The following is a description of a gene set: Any process that activates or increases the frequency, rate or extent of protein localization to synapse. studied in species Mus musculus Mouse Gene Set: GOBP_POSITIVE_REGULATION_OF_PROTEIN_LOCALIZATION_TO_SYNAPSE, and this is the list of marker genes: Nlgn3, Mapt, Nlgn1, Clstn3, Nlgn2